Given this list of marker genes ATP13A5, ACKR2, EPHA1, RPA1, COBLL1, PLD4, ZNF367, RASEF, FGD5 (NCBI Gene Id 152273), WNT9A, NR4A1, CDH5, REG1B, LIMS3, HLA-DRB5, LOXHD1, COL25A1, CXCL6, CIITA, LRRCC1, ARHGAP29, MYOF, ALDH1A2, CPXM2, DLK1, ALG1L2, CA5A, AFF2, NEURL1, H2BC7, PLCB1, A2M, SETD7, APCDD1L, G6PC2, MS4A14, FAM241A, ADAM12, ENTHD1, HLA-DMB, COL4A1, SPIB, PTPRD, CDYL, PLCL1, SEPTIN10, POLR3G, FTO, RAMP3, TGFBI (transforming growth factor beta induced), UTRN, DPYSL3, FAM83D, STK26 (NCBI Gene Id 51765), EFNA5, POC1B, LILRA4, SERPINB8, ZNF660, MAP3K7CL, TFPI2, CYCS, CXCL12, HEMGN, LEPR, ENKUR, IGFBP5, TECTA, KCNAB1, CA8, SIGLEC12, KRTAP29-1, KIF26A (NCBI Gene Id 26153), SLC4A8, CD34, SNAP25, AGBL3, LIG4, SYNPO, SLC18A3, STRBP, PHEX, MLH3, PRIMPOL, STXBP6, COA1, MAPK10, PACSIN1, TGFB2, DMD, FAM107A, P2RY10, CAVIN1, KDR, NXT2 (nuclear transport factor 2 like export factor 2), CEP128, ENSG00000285976, HLA-DQA1, WWOX, IL3RA, TNS1, AVPR1A, ERC2, KCTD12, CA2, ZNF117, ATP13A4, TAS2R14, TNFRSF21, CAVIN2, GPR55, SH2D1A, SMIM36, NLGN1, RETREG1, BTLA, GPIHBP1, CLEC10A, SHTN1, KRT5, LDB2, GRHL1, PPM1E, MECOM, WDFY4, HAT1, CLEC4C, ZC3H12B, ADORA2A, ENTREP2, MAGOHB, HLA-DQB1, TNFSF18, IGF2, NRN1, NOMO1, RNF212B, HLA-DOA, DPYD, COL4A2, KCND3, ARPIN, CPVL, ALDH1A1, MPEG1, SLC37A2, CCDC50, CPAMD8, ERV3-1, VEGFA, IL33, FLNB (filamin B), ZNF490, CPNE4, PHACTR3, OR11L1, DCDC2, GPR88, BEND2, ITGB3BP, WLS, IL7R, LGALS2, ZNF257, CTNND2, ANKDD1B, PARD3B, MSANTD3-TMEFF1, LYSMD3, TMEM70, CEMIP, DNAH12, SDK1, SPC25, ZNF347, IFT70A, P2RY12, UGT2B28, PDCD1LG2, ZNF438, KRTAP17-1, VWA8, PID1, TMEM150C, TPPP3, SCIN, HECW2, MS4A7, GLYATL2, GARIN1B, RGS18, UNC5B, PAX5, PREX2, ANKRD55, SLFN14, PAPPA, CCDC103, DACH1, SASH1 (SAM and SH3 domain containing 1), ACVRL1, HSD17B3, COL15A1, ENAH, ACE, MYEOV, SMAD5, MINAR1, MFAP3L, IRF8, ZNF229, ACADM, DAB2IP, CLIC5, YAP1, CXCL5, AFF3, ZNF665, BANK1, PF4V1, DYTN, HLA-DRA, STEAP1B, TBX3, here is a description of the gene set: Strongly downregulated genes from differential gene expression analysis of platelets from 10 combined ICU and Non-ICU COVID-19 patients and, for comparison, 5 healthy donors Human Gene Set: MANNE_COVID19_COMBINED_COHORT_VS_HEALTHY_DONOR_PLATELETS_DN from publication Manne BK, Denorme F, Middleton EA, Portier I, Rowley JW, Stubben C, Petrey AC, Tolley ND, Guo L, Cody M, Weyrich AS, Yost CC, Rondina MT, Campbell RA (PMID 32573711) studied in species Homo sapiens Thrombotic complications in patients with COVID-19 are common and contribute to organ failure and mortality. Patients with severe COVID-19 present with hemostatic abnormalities that mimic disseminated intravascular coagulopathy associated with sepsis with the major difference being increased risk of thrombosis rather than bleeding. However, whether SARS-CoV-2 infection alters platelet function to contribute to the pathophysiology of COVID-19 remains unknown. In this study, we report altered platelet gene expression and functional responses in patients infected with SARS-CoV-2.